The following is a description of a gene set: from publication Darce J, Rudra D, Li L, Nishio J, Cipolletta D, Rudensky AY, Mathis D, Benoist C (PMID 22579475) Genes up-regulated in splenocytes from Foxp3-Fusion-GFP B6 mice: T reg (FOXP3+) versus T conv (FOXP3-) cells. studied in species Homo sapiens Human Gene Set: GSE37605_TREG_VS_TCONV_C57BL6_FOXP3_FUSION_GFP_UP The aim of this study was to quantify the impact of chimeric Foxp3-GFP protein on the Treg cell transcriptional program., and this is the list of marker genes: RBP7, NALF1, TM4SF5, CACNA2D3, BASP1, NEFH, CRMP1 (NCBI Gene Id 1400), IL25, CCL22, DNAJC28, CCDC117, RBM3, RGS7, IKZF2, GOLGA8A, BHLHA9, CENPS, KRT79, PCLO, ATP6V0D2, PLS1, LPP, IL21, CMYA5, MANF, TAAR1, SLC22A13, UBA5, CCDC30, PTN, VSIG10L, MAPK12, SLC5A5, SGK2, GULOP, NANOS1, SAMD7, S1PR2, FGF13, KRTAP11-1, MPZ, CELF4, GALNT9, SLC27A3, TNFSF14, AHNAK (AHNAK nucleoprotein), A1BG, ARL4C, TRAPPC3L, CLEC2D, LAMA3, MAPK13, CRPPA (CDP-L-ribitol pyrophosphorylase A), CD52, MREG, KCNK10, ATCAY, HTR6, PYCR1, KCNA3, FRG1, GJD3 (NCBI Gene Id 125111), KCNMB4, AQP4, FABP7, RAB42, CD33, NTRK3, SPON1, FZD6, CES2, MAFA (NCBI Gene Id 389692), CNTN1, TNP2, NPPA, TBX21, CYGB, PAX8, BAALC, PBLD, FUBP1, LAMP3, TEX15, SNORD14E, RALBP1, TTN, HSPA4, SNPH, RGS13, FER1L4, WDR17, HSP90B1, FANK1, NR3C2, INSM1, NPAS2 (neuronal PAS domain protein 2), SEC22A, TSNAXIP1, RASSF6, DNAJC3, RNF43, NT5E, DNAJC25, TRIM63, DMBX1, FAM83C, RPL7A, SCIN, TUSC1, ZBTB42, SLC22A15, SLC7A11, PIM2, CALHM6, GLIPR2, SOSTDC1, MIR218-1, STX11, ITGB8, SMPDL3B, EPHA5, UNC45B, CUBN, SDCBP2, HMGA2, N4BP1, PLIN3, ASCL2, PCBD1, SLCO4A1, SYT11, HPSE, REPIN1, ALDOC, THOP1